The following is a description of a gene set: studied in species Mus musculus Human Gene Set: HUMMERICH_BENIGN_SKIN_TUMOR_DN Genes down-regulated in benign skin tumors (papilloma) induced by treatment with DMBA and TPA chemicals in the two stage skin carcinogenesis model. from publication Hummerich L, Müller R, Hess J, Kokocinski F, Hahn M, Fürstenberger G, Mauch C, Lichter P, Angel P (PMID 16247483) Chemically induced mouse skin carcinogenesis represents the most extensively utilized animal model to unravel the multistage nature of tumour development and to design novel therapeutic concepts of human epithelial neoplasia. We combined this tumour model with comprehensive gene expression analysis and could identify a large set of novel tumour-associated genes that have not been associated with epithelial skin cancer development yet. Expression data of selected genes were confirmed by semiquantitative and quantitative RT-PCR as well as in situ hybridization and immunofluorescence analysis on mouse tumour sections. Enhanced expression of genes identified in our screen was also demonstrated in mouse keratinocyte cell lines that form tumours in vivo. Self-organizing map clustering was performed to identify different kinetics of gene expression and coregulation during skin cancer progression. Detailed analysis of differential expressed genes according to their functional annotation confirmed the involvement of several biological processes, such as regulation of cell cycle, apoptosis, extracellular proteolysis and cell adhesion, during skin malignancy. Finally, we detected high transcript levels of ANXA1, LCN2 and S100A8 as well as reduced levels for NDR2 protein in human skin tumour specimens demonstrating that tumour-associated genes identified in the chemically induced tumour model might be of great relevance for the understanding of human epithelial malignancies as well., and this is the list of marker genes: MYH2, MYH8, IGFBP5, SCD, TNNI2, PCDH12, PLXNB2, ACTN3, ALB, TNNT3, CFD, AFF1, COX6A2, MYH4, MYH1, CKM, MYL11, TNNC2, S100A3, ATP2A1